The following is a description of a gene set: Human Gene Set: HP_BILATERAL_PTOSIS species: Homo sapiens Bilateral ptosis, and this is the list of marker genes: TK2, NGLY1, ACBD5, ISCU, COLQ, PDX1, PAH, KDM1A, PHOX2A, NRAS, CLCN3 (chloride voltage-gated channel 3), CERT1, SOS1, GSN, RAD21, DBH, PIGA, ATP6V1B2, ADNP, TUBA1A, TBC1D24, INS, CRELD1, SETD5, OPA1, PDZD8, TYMS, POLG, AEBP1, DNM1L, RNASEH1, RYR1, TUBB2B, CDC42BPB, PACS1, STAC3, KCNH1, KCNJ11, MAF, WT1, SPECC1L, DGUOK, POLRMT, PLEC, SCN4A (NCBI Gene Id 6329), NARS2, COL2A1, FLNA, STAT3, TUBB3, TWIST1, NAA10, RRM2B (ribonucleotide reductase regulatory TP53 inducible subunit M2B), KDM6A, NOVA2, KIF21A, IGF1, LAMB2, IDUA, LRP12, AUTS2, GCK, ODC1, ABCC8, CHRNG (NCBI Gene Id 1146), PAX6, KMT2D, ZNF407